The following is a description of a gene set: Mouse Gene Set: GOBP_REGULATION_OF_RESPIRATORY_GASEOUS_EXCHANGE Any process that modulates the frequency, rate or extent of the process of gaseous exchange between an organism and its environment. studied in species Mus musculus, and this is the list of marker genes: Atp1a2, Nmbr (NCBI Gene Id 69412), Grpr, Phox2b, Slc5a3, Mtg1, Nlgn1, Pbx3, Nlgn2, Mtg2, Gsx2, Nr4a2 (nuclear receptor subfamily 4, group A, member 2), Glra1, Gls, Nlgn3, Grin1, Mecp2, Adora1, Fto, Tshz3, Cc2d1a, Phox2a, Tlx3, Ntsr1, Nmb, Grp, Pask